Given this list of marker genes FXYD2, FXYD1 (NCBI Gene Id 5348), FXYD6P3, ATP1B3, FXYD5 (FXYD domain containing ion transport regulator 5), ATP1B2, FXYD6, FXYD4, FXYD3, FXYD7, ATP1B1, here is a description of the gene set: Any process that modulates the frequency, rate or extent of sodium ion export across the plasma membrane. studied in species Homo sapiens Human Gene Set: GOBP_REGULATION_OF_SODIUM_ION_EXPORT_ACROSS_PLASMA_MEMBRANE